Given this list of marker genes Bmp5, Bmp2, Rest, Atp1a1, Dkk3, here is a description of the gene set: Mouse Gene Set: GOBP_NEGATIVE_REGULATION_OF_GLUCOCORTICOID_METABOLIC_PROCESS studied in species Mus musculus Any process that stops, prevents, or reduces the frequency, rate or extent of the chemical reactions and pathways involving glucocorticoids.